Given this list of marker genes COL21A1, GPR176, ARSJ, MECOM, MERTK, PDK3, PAPSS1, ZBTB7B, ARC, ITPR1, TRIM47, HEY1, TMEM47, TRABD2A, MLLT1, PCSK2 (NCBI Gene Id 5126), CDK19, METTL27, RUNX1T1, CALHM2, ARHGAP4, LTC4S, SERPINE2, SOX6, H2BC21, ATP2A3, ASRGL1, RFC3, CRYBG1, THSD7A, PDLIM1, GCNT2, QSOX1, SKIL, SSTR1, FAT4 (NCBI Gene Id 79633), FGFR3, DENND3, CRIP1, SLC2A6, PREX2, TTLL3, LTBP1, RASD1, PRRT1, KAZALD1, NICOL1, PELI1, STK38L, ADAMTS6, KANSL3, PALLD, CFH, RAB32, BVES, MMP16, HLA-DRB1, DENND11 (NCBI Gene Id 57189), GCH1, NOS1, MXRA7, SLC18B1, ARID5A, HMCN1, DUSP4, KCNN4, CAMK1D, SCGB3A1, ORAI1, MX1, DKK2, APLP1, ENTPD1, HEY2, C19orf33, HIP1R, SH3BP4, MMEL1, SMAD6, LPCAT2, LTBP4, MMP15, SMAD7, IL11RA, C14orf132, SULT1B1, SLC16A2, MSX1 (NCBI Gene Id 4487), FAM241A, ARL15, PRR7, IFITM1, TMEM100, TMEM38A, EVA1C, LAMA5, TSPAN2, COL3A1, IFI44L, HSBP1L1, RIPK3, BMX, ST6GALNAC1, PDE4D, VEGFC, PIK3C2B, ATP13A3, RGMB, FAM107A (family with sequence similarity 107 member A), SENP7, C1orf115 (chromosome 1 open reading frame 115), ST3GAL4, AOPEP, CSRNP1, TNFAIP8, PLLP, GFOD1, ABR, GPER1, RNLS, SLC48A1, TRAM2, NSG1, ITPR2, JAG2, CLGN, SELPLG, TGFB2, GPRIN3, GRIP2, FAM234A, GCNT1 (glucosaminyl (N-acetyl) transferase 1), PLCB4, NOMO3, COL6A1, TIAM2, FBLN2, PTGIS, PLAC9, KITLG, EDNRB, TMED7, DHH, SULT1E1, EGFLAM, SH2D4A, TNKS1BP1, ID2, FOSL2, APOA1, CCDC71L, NR4A1, CKB, MAMLD1, ADA2, CPAMD8, FCSK, SULF1, DGKA, PKN3, SPATA13, GATA6, SSUH2, AIF1L, CHMP4C, DBNDD2, TOB1, GCHFR, PLPP1, ITGB4, TSKU, TRH, CTSC, GIPC2, COL9A3, DSTYK, TNFRSF1B, APOL4, ROBO2, PTPN14, ABCC4, CGNL1, SLC12A2, CYP26B1, HSD17B14, NUAK1 (NUAK family kinase 1), TMEM168, GATA6-AS1, MCTP1, CDC42EP3, KCNN3, LINC00440, MPPED2, PRXL2C, CXCR4, SWAP70, FZD6, HS6ST1, FILIP1L (filamin A interacting protein 1 like), FBN1, S1PR4, MYO1E, SOX5, EPHA4, TANC2, ASS1, PCSK5, MCC (MCC regulator of WNT signaling pathway), VPS37C, TOX2, SNX18, RRAS (RAS related), GNA14, COL1A2, PTGDS, PI16, SYT1, FUT8, SYT11, RFTN1, CXCL12, SEMA3G, EGFL8, KCNQ2, FBLN5, SELENOM, HBEGF, CLIC3, MGP, MTMR11, C1QTNF6, PDE10A, GOLIM4, NOVA1, EPS8, BCAT1, NPW, ENTPD2, SRGN, GUCY1A1, JAG1, VAMP8, MET, PIK3R3, HES4, GLUD2, CHL1, AFAP1L2, SLC8A1 (solute carrier family 8 member A1), B3GNT2, F2R, TMC7, CYB561D2, ITPR3, ST8SIA6, SIDT1, RAPGEF3, CYTH3, PITPNM1, TAFA5, ALPL, ADGRL1, GJA5, STAT6, ERBB2, NR4A2, LYPD2, KLF12, CD58, USP53, PLCG2, MEX3C, SYNPO, SOX13, FGR, CEP15, RNF144B (NCBI Gene Id 255488), IFI6, GULP1, GBP2, SEMA3F, MYOF, GRIA2, MIR503HG, FGF18, SYNJ2, here is a description of the gene set: species: Homo sapiens Arterial endo from publication He P, Lim K, Sun D, Pett JP, Jeng Q, Polanski K, Dong Z, Bolt L, Richardson L, Mamanova L, Dabrowska M, Wilbrey-Clark A, Madissoon E, Tuong ZK, Dann E, Suo C, Goh I, Yoshida M, Nikolić MZ, Janes SM, He X, Barker RA, Teichmann SA, Marioni JC, Meyer KB, Rawlins EL (PMID 36493756) Human Gene Set: HE_LIM_SUN_FETAL_LUNG_C3_ARTERIAL_ENDOTHELIAL_CELL